The following is a description of a gene set: Human Gene Set: KEGG_MEDICUS_VARIANT_MUTATION_INACTIVATED_PROK2_TO_PROK_PRKR_GI_ERK_SIGNALING_PATHWAY Pathway Definition from KEGG: PROK2* -> PROKR1/2 -> GNAI -> ERK Mutation-inactivated PROK2 to PROK-PRKR-Gi-ERK signaling pathway. Pathway ID: N00880. Pathway type: Variant. Pathway class: nt06361 Hypogonadotropic hypogonadism. species: Homo sapiens, and this is the list of marker genes: PROKR1, MAPK3, GNAI3, MAPK1, GNAI1, PROKR2, GNAI2, PROK2 (prokineticin 2)